The following is a description of a gene set: Mouse Gene Set: GOBP_MEMBRANE_RAFT_ASSEMBLY species: Mus musculus The aggregation, arrangement and bonding together of a set of components to form a membrane raft, a small (10-200 nm), heterogeneous, highly dynamic, sterol- and sphingolipid-enriched membrane domains that compartmentalizes cellular processes., and this is the list of marker genes: Iqgap1, Anxa2, Flot1, Ilk, Cav1, Lrch4, Emp2, Rftn1, Clec2i, Cav2, Cav3, S100a10, Col6a1, Pacsin2